Given this list of marker genes KIDINS220, PAX2, CPAMD8, PEX2, PEX5, BRAF, B4GAT1, here is a description of the gene set: The presence of developmental dysplasia of the optic nerve. Optic nerve dysplasia studied in species Homo sapiens Human Gene Set: HP_OPTIC_NERVE_DYSPLASIA